Given this list of marker genes Phyhd1, Palld, Nsg1, Atg7, Pcdhb10, Zswim7, 4933436P19Rik, Tceanc2, Cel, Adam8, Avl9, Egr2, Rai14, Agr2, Rep15, Adh1, 9530046B11Rik, Ebf3, Aqp5, Ang, Dock10, Dhh, Igf1, Cebpa, Abtb1, Gpalpp1, Daam2 (dishevelled associated activator of morphogenesis 2), Lrrc49, Zbtb42, Fibin, Rnf122, Styxl2, Ptpn5, Lyve1, Vdr, Eif2s1, 1700034J04Rik, Tmem59l, Eya3, Pgpep1l, Muc16, Agps, Ttc3, Cyp1b1, Selp, Prkg1, Ttc34, Or11h4, Slco6c1, Sesn3, Foxj1, Cfap119, 9830166K06Rik, Ubap2, Tmco2, Nf1, Sh2d5, Ascc1, Plp2, 7630403G23Rik, Metap2, Kdm5d (NCBI Gene Id 547415), Csl, Ctnnd2, 4930566F21Rik, Foxq1, Abl1, C1qtnf6 (C1q and tumor necrosis factor related protein 6), Npvf, C1qtnf5, Prmt7, Pou3f2, Egfl7, Nanog, Syt13, St8sia5, Lrrc8a, Cyp2f2, Mfrp, Gml2, P2rx6, Ubl3 (ubiquitin-like 3), 4930422I22Rik, Ndnf, C3, Spire1, Gap43, Sub1, Gng4, P2rx5, Ubl4b, Nudt14, Sh2d1b2, Osr2, Kat6a, App, Dhrs3, Uchl1, Cpsf4l, Tslp, Slc26a2, Oprm1, 5730507C01Rik, Rsu1, Cstf2t, Lrat, Tmed6, Il17re, Frrs1l, 4930565D16Rik, Bbs7, Fbn2, Thbs1, B230217C12Rik, Cog5, Ramp3, Rapgef3, 5730507A11Rik, Nfx1, Trip11 (thyroid hormone receptor interactor 11), Cd40, Lrrc71, St6galnac2, Ptpro, Cd48, Nol4l (NCBI Gene Id 98957), Uba6, Defb41, Ly6g6c, Pdk2 (NCBI Gene Id 18604), Ccdc92b, Ugt2b1, Mmp10, Anln, Fli1, Vta1, Mpped2, Zfp568, Lce1a1, Epb41, Tshz1, Lin7b, Reln, Adam6a, Nfib, Depp1, Dusp22, Reg2, Ndn, Mxra8, Tnip2, Aknaos, Mgll, Sf3b6, Snapc3, Ube2l6, Ncald, Msl3l2, Cyria, Arid5b, Csn1s2a, St18, Fbxo32, Crmp1, Iqub, Six2, Celf4, Aldh6a1, Angpt1, Rho, Pdcl, 9430092D12Rik, Ccn3, Chodl, Spon2, Ntf5 (neurotrophin 5), Mcu, Zbtb47, Iah1, Crtam, Polq, Phf14, Ankdd1b, Crebrf, 9530086P17Rik, Ubd, Bmf, Gbp8, Emid1, Gpr162, Cxcl1, Epha7, Sytl2, Irak4, Gabre, C1d, Hsd17b11, Mfhas1, Tmsb10, Zbtb1, Gdpd2, Itih2, Emb, Ptpn3, Psmb11, Mustn1 (musculoskeletal, embryonic nuclear protein 1), Ror2, Sparcl1, Cyp2a4, Uroc1, Arhgef17, Lypd6, Anp32a, Trabd2b, Baz2b, Kyat1, Slc35d3, Chd1l, Clcn5, Pdzk1ip1, Acta2, Rnft1, Prxl2b, Zpbp (NCBI Gene Id 74977), Negr1, Rbp1, Chgb, Rab38, Peg10, Slc18b1, Nrarp, Scube2 (NCBI Gene Id 74421), Inpp5k, Tmem238l, Nipa1, Ctag2, Mrgprf, Prpf38a, Igdcc3, A230001M10Rik, Cbr1, A930002C04Rik (RIKEN cDNA A930002C04 gene), Atp9a, Dock8, Mapt, Tmem144 (transmembrane protein 144), Ms4a6d, Tmem53, Tnfrsf25, Paqr5, Sorcs1, 9330121K16Rik, Mgst2, Ccdc187, Pdzd11, Srpk3, Syt11 (synaptotagmin XI), Grhl3, A930002H02Rik, Lpin3, 4930517G19Rik (NCBI Gene Id 74727), H3c14, Clmp, Nfyc, Lyrm9, B3gnt6, Tet1, Enkur, here is a description of the gene set: The reciprocal chromosomal translocation t(4;11) is correlated with infant, childhood, adult and therapy-related high-risk acute leukemia. Here, we investigated the biological effects of MLL.AF4, AF4.MLL or the combination of both reciprocal fusion proteins in a conditional in vitro cell culture model system. Several parameters like cell growth, cell cycling capacity, apoptotic behavior and growth transformation were investigated under physiological and stress conditions. Co-transfected cells displayed the highest resistance against apoptotic triggers, cell cycling capacity and loss-of-contact inhibition. These analyses were complemented by gene expression profiling experiments and specific gene signatures were established for each of the three cell lines. Interestingly, co-transfected cells strongly upregulate the homeobox gene Nanog. In combination with Oct4, the Nanog homeoprotein is steering maintenance of pluripotency and self-renewal in embryonic stem cells. Transcription of Nanog and other stem cell factors, like Oct4 and Bmi1, was verified in biopsy material of t(4;11) patient cells which express both reciprocal t(4;11) fusion genes. In conclusion, the presence of both reciprocal MLL fusion proteins confers biological properties known from t(4;11) leukemia, suggesting that each of the two fusion proteins contribute specific properties and, in combination, also synergistic effects to the leukemic phenotype. Mouse Gene Set: GAUSSMANN_MLL_AF4_FUSION_TARGETS_G_UP from publication Gaussmann A, Wenger T, Eberle I, Bursen A, Bracharz S, Herr I, Dingermann T, Marschalek R (PMID 17130830) Up-regulated genes from the set G (Fig. 5a): specific to cells expressing both MLL-AF4 and AF4-MLL fusion proteins. species: Mus musculus